Given this list of marker genes Cenpq, Ppp2r5b, Cenpn, Ube2d1, Zwint (ZW10 interactor), Ckap5, Rps27, Kif2a, Dync1h1, Cenpt, Anapc11, Cdc23, Rps27rt, Ppp2r5e, Cenpp, Spdl1, Ska2 (NCBI Gene Id 97710), Ppp2cb, Cenpm, Nup133, Cdca8, Plk1, Ppp2r1b, Itgb3bp, Nup98, Clasp1, Nup85, Sgo2a, Ppp2r1a, Incenp, Cdc20, Anapc7, Clip1, Ppp2r5c, Nde1, Ppp2ca, Ahctf1, Taok1, Ndel1, Dync1li2, Ska1, Cenpi, Cenpu (NCBI Gene Id 71876), Dync1i1, Cdc26, Ube2s, Dync1li1, Dync1i2, Anapc5, Seh1l, Cdc16, Nup37, Nup107, Nudc, Pmf1, Rangap1, Bub3, Nup43, Nuf2, Mis12, Bub1, Cenph, Kntc1, Cenpf, Nsl1, Dynll2, Dsn1, Anapc4, Dynll1, Cenpk, Cenpa, Ppp2r5d, Kif2b, Spc24 (SPC24, NDC80 kinetochore complex component, homolog (S. cerevisiae)), Rcc2, Anapc16, Anapc10, Mapre1, Clasp2, Anapc15, Cenps, Kif2c, Cenpl, Cenpo, Ppp1cc, Xpo1, Cdc27, Mad1l1, Mad2l1, Ndc80, B9d2 (B9 protein domain 2), Cenpe, Pafah1b1, Zwilch, Sec13, Bub1b, Nup160, Anapc1, Sgo1, Ranbp2, Cenpc1, Aurkb, Zw10, Ube2e1, Ercc6l, Anapc2, Ube2c, Kif18a, Spc25, Ppp2r5a, here is a description of the gene set: Mouse Gene Set: REACTOME_MITOTIC_SPINDLE_CHECKPOINT Mitotic Spindle Checkpoint studied in species Mus musculus